The following is a description of a gene set: Binding to an adenyl nucleotide, an adenosine esterified with (ortho)phosphate. Human Gene Set: GOMF_ADENYL_NUCLEOTIDE_BINDING studied in species Homo sapiens, and this is the list of marker genes: FCSK, CDK14, UBE2G2, RNLS, SEPHS1, CHD7, ALPK2, MYO9B, ITPKA, SULT2A1, MTHFD1L, EHD3, CHD8, PSMC5, CDK10, DDX39A, NLRP2, STK38, STYK1, PSTK, DGKQ, ABCC9, LRGUK, PAK5, TREX1, STARD9, LTK, DPH6, MCCC2, ATP10B, MASTL, ATP2A2, MAPK10, CARNS1, HSP90AB3P, ATP13A3, IQCA1, EPRS1, MLH1, MAPK3, DAPK3 (NCBI Gene Id 1613), ATAD1, BRSK1, HADH, ENPP1, TRIB3, UGDH, ABCB6, RUVBL2, FER, CSF1R, MAT2A, DNAH5, RNGTT (RNA guanylyltransferase and 5'-phosphatase), RAD50, NEK1, DYRK1A, SIRT7, ABL1, CSNK1G3, NEK4, PIP5K1C, TRIT1, PANK3, DHX38, DHX36, PFKL (NCBI Gene Id 5211), PPIP5K1, PIK3CB, NLRP8, CDC6, PC, KARS1 (lysyl-tRNA synthetase 1), MUSK, PSMC6, PRKACG, DALRD3, MYO1G, ATP9A, HFM1, ADCK2, MYH6, PRKY, CNGA1, HIPK1, ASPDH, ABCC2, FARS2, CLCN7, NEK7, MYH9 (myosin heavy chain 9), PAK1, UBA1, SCYL2 (NCBI Gene Id 55681), TXK, SMCHD1, TOP2A, EPHA2, GUK1, SPG7, FN3K, ITPR3, POPDC2, DDX27, PIK3C3, MCM9, DDX23, CLPB, SBK1, CACNA1B, MARS2, DDX60L, PRKAG3, WRN, SIRT1, PDE2A, UBE2L3, FBP1, HELQ, TDRD12, MAP3K10, DNAH9, DNAH7, ACSL6, PRKAR2A, CCT4, POR, DNAH1, RIOK3, HSPA2, PMVK, RIGI, SRPK1, SLC22A5, MCMDC2, ORC5, DGKG, XRCC5, ULK4 (unc-51 like kinase 4), DDX50, NRBP1, DHX37, FPGS, DDX51, CKMT1A, ABCB1, ALDH1A1, FIGNL1, ATP2B2, DCLK2, TTLL12, ABCG5, EIF4G1, AK4, CHORDC1, PDK2, PGD, WNK4, MYO9A, UBE2O, NLRP7, NTRK2, PAPSS2, DNA2, GLUL, UBE2C, PGS1, HSPA5, DDX19B, CMPK1, SCYL3, HSPA6, EPHA5, PHKG1, HSP90AA5P, CKB, AAK1, KCNAB1, CDK13, NRBP2, HLCS, SUCLG2, ACSM2A, NEK11, ATP2A1, GCK, IRAK1, DNHD1, CCT2, STK32B, FIGNL2, BAG3, CHST15, ATP2B3, ATP8B3 (ATPase phospholipid transporting 8B3), ACSBG1, MAP3K4, CKM, ACTA1, PKLR (pyruvate kinase L/R), EGFR, PRKAR2B, EHHADH, IDNK, KIF14, EHD4, YARS1, FGFR3, KIF11, NLRP9, TAF1 (NCBI Gene Id 6872), CDC123, PIK3C2A, ITM2B, HPGD, UBE2D2, MAPKAPK2, PHGDH, EPHB2, ABCC1, DTYMK, NEK8, MAPK4, IDE, DPYD, GLUD2, ATP8B4, RPS6KC1, PCCB (NCBI Gene Id 5096), AURKC, CRYZ, ORC1, ADCY1 (NCBI Gene Id 449484), STK17A, SYN1, FMO4, ITK, PI4K2A (phosphatidylinositol 4-kinase type 2 alpha), RUNX3, OPLAH, DCK, BCS1L, TIMM44, BUB1B, JAK1, PAK2, BAG5, RHOBTB3, FMO5, KIF18B, MYO3B, BTAF1, HNRNPU, TRIP13, KIF25, KIF12, FASTK, CAMKK2, EPHA4, ACACA, CCT8, TTLL11, UBE2B, HSPA1A, TTLL5, GALK1, ENTPD8, GSR, UHMK1, EPHB4, CCT5, TLK2, ACSF3, FAM20B, MYO5A, ACTR2, STK32C, KIT, RPS6KB2, ACSS3, ACOT12, WRNIP1 (NCBI Gene Id 56897), HSP90AB1, UBE2T, PDK4, NAIP, LONP2, RUNX2, RPS6KA5, ACTA2, CLPX, AFG1L, ROS1, KIF13B, UBE2K, CRYL1, PIM2, IQCA1L, MYO18B, CDKL5, PNPLA8, MORC2, STK3, DHX34, PIK3CD, TTN, NAV2, STING1, ERCC6L2, MYO10, ATM, NUAK2, KIF2A, ITM2C, FLAD1, ADCY2, HYOU1, HSP90B1, PDE4B, NLRP12, ATP2A3, UBE2Q2, FLT4, PKN1, NUBPL, MAP3K9, NAV3, TESK2, MYO5C, PRKD3, DUOX1, ALDH1A3, PIK3C2B, TAOK2, RAD54B, STK4, PPCS, DYRK1B, UBE2G1, MYH3, ZGRF1, UBE2I, EIF4A1, MAPK13, TK1, MATK, GRPEL1, IDH1, CHUK, GRK2, EIF2AK3 (eukaryotic translation initiation factor 2 alpha kinase 3), DDX11L8, DDX18, CBR3, PKN2, TWNK, TNK1, MCM3, ATP6V1B1, SYN3, RPS6KA2, CLK3, GRK4, RFC2, BDH2, ATP9B, RARS1 (arginyl-tRNA synthetase 1), NUDT6, TK2, RAPGEF4, SIK3, MOS, CAMK4, FYN, NOS3, MAP4K3, ABCG1, NLRP3, CNGA2, DDX4, NLRC5, SELENOO, KIF2B, STK31, NUBP1, SMC4, MOK, HELLS, PFAS, KIF13A, PFKFB1 (NCBI Gene Id 5207), AFG3L2 (NCBI Gene Id 573970), KIF26B, ALPK1, MYLK2, TBK1, BAZ1B, BVES, AK1, ACTG1, ERCC6, PRKX, MET, ZRANB3, GART, FICD, MAB21L1 (NCBI Gene Id 4081), WEE2, CDK6, RUNX1, CTBP1, NDOR1, UCK2, OAS3, PDE4A, TWF2, TP53RK, PKMYT1, WEE1, DYRK2 (NCBI Gene Id 8445), GRK5, NADK, NADSYN1, ACSS1, ACVR1B, PARP15, ACTR1A, PMS1, RAD54L, CLP1, RET, HSP90AB4P, ABCA10, RPS6KB1, ROR1, CCT8L1P, MELK, ACTR1B, CLCN5, TLK1, PI4KB, CHEK2, SRC, ABCB7, NNT, DARS2, AGK, HSPD1, RFC1, TNIK, KIF2C, SLC27A5, NMRK1, KCNJ10, TTLL9, IDH3G, CDK5, CNGA4, IRAK4, KCNJ8, MINK1, ADCY5 (adenylate cyclase 5), TTLL10, SMARCA2, EEF2K, TOR1A, MYO19, CLCN4, UBE2U, ABCA2, HSPA9 (heat shock protein family A (Hsp70) member 9), HCK, TRIB1, RIMKLB, AK3, NLRP13, PBK, KIF19, STRADA, HK1 (hexokinase 1), UBE2E2, HSP90AA2P, BLM, DDX60, DDX17, NLRP11, ATP13A4, CPS1, PRKCG, DHX40, ATP8B2, NME7, PAPOLA, DNAJA4, PEX1, LIMK2, BMPR1A, ACVR1C, MAP4K1, SARS2, GRK6, TTF2, DHX9, ETNK1, CCT6A, DHX57, EIF2AK4, GK2, PFKM, EP400, STK26, ATP7B, KIFC3, HSP90AA4P, ITPKB, MSH2, CDKL4, NEK3, RAD51C, MMAB, DCLK3 (doublecortin like kinase 3), MCM7, SWAP70, RTCA, POMK, ABCC11, DDX11, UPF1, GLYR1, HMGCR, SIK2, FGR, DDX56, PRPS1L1, RPS6KL1, DDX39B, CDK2, ABCC4, SRCAP, SLFN5, RAD54L2, IPPK, TRPM4, KATNA1, MAPKAPK3, SULT1C3, MARS1, ATP11B, PTK2B, CDK20, MYO5B, DDX52, PAICS, KIF17, PDIK1L, RBKS, RYR1, YTHDC2, ULK2, FMO1, PANK2, DARS1, KIF20A, TTBK1, DAPK1, SGK1, MCM6, ABCD1, ATRX, OXSR1, PI4KA, NSF, UBA2, PAN3, GK, PDK3, FMO2, VCP, TEK, NTRK3, CASK, AMHR2, BMX, ACTBL2, DDX20, ATP13A5, ADCY7, ACSF2, UBE2E1, NLRP14, KIF9 (kinesin family member 9), PPP5C, PRKCD, TTK, TYK2, SBK3, NLRP4, PRKAG1, TRAP1, PMS2 (NCBI Gene Id 91271), PIM3, SLC12A3, ABCD2, FBH1, MSH4 (mutS homolog 4), HSPA14 (heat shock protein family A (Hsp70) member 14), MCCC1, RECQL, ULK3 (unc-51 like kinase 3), TRNT1, PAPSS1, SNRNP200, CDC7, HCN4, CENPE (centromere protein E), MAT1A, TTLL8, RUVBL1, ACLY, MYO1C, PRPS1, SIRT3, ABCA3, CBR4, ABCE1 (NCBI Gene Id 6059), STK39, SLC22A4, RAD51, LYN, AK7, MAP4K5, ACACB (acetyl-CoA carboxylase beta), DDX1, CCAR2 (NCBI Gene Id 57805), AKT3, MTHFD1, HKDC1, ABL2, PEX6, LIG4, GK5, NAXD, NTRK1, VPS4A, EIF4A3, ITPKC, PRKAR1A, TRPM7, MAGI1, FKBP4, ACTB, BRSK2, P2RX3, OLA1, PIP4K2B (phosphatidylinositol-5-phosphate 4-kinase type 2 beta), THRAP3, DNAH3, PRKAR1B, TP53I3, TAOK1, SPR, ERCC6L, CDK17, DDX10, CLK2, MYO1B, HELZ, MAST2, BBS12, CHKB, ABCC10, IRAK3 (NCBI Gene Id 11213), DDX3Y, ASS1, CERK, ABCA8, FN3KRP, DGUOK, EPHA6, CSNK1G2, DDX3X, KIF3B, CDK7, BRAF, MAPK12, NEK10, LATS2, DGKA, CNBD2, P2RX2, TTLL13, NAGK, DNAH8, MYO1D, MKI67, MAPK9, KIF4A, PEAK1, VPS4B, RARS2, RAPGEF2, DDX24, MCM4, BMS1, ERN1, PANK1, SLFN14, FIGN, NMNAT2, PTK6, SLC19A1, ITPK1, CFTR, NEK6, SORD, ATP6V1B2, NUBP2, VRK3, FGFR2, IARS1, ADCY9, SNRK, PI4K2B, CSNK2A3, CDC42BPG, ACSL4, KIF5A (NCBI Gene Id 84710), DUS2, CHD5, AKR7A3, HSPA12B, ACSM1, MKNK1, SCYL1, PNKP, FGFR4, MAP2K7, KIF1C, NPR1, SMC1B, MAP3K7, GAK, TARS3, ATP8A2, KIF23, ATP1A3, SUPV3L1, IP6K1, ATP13A1, RFC5, NME2 (NME/NM23 nucleoside diphosphate kinase 2), BMP2K, PTK7, CAD (carbamoyl-phosphate synthetase 2, aspartate transcarbamylase, and dihydroorotase), TAP1, SBK2, NOD1, NLRC4, TRPV1, KDSR, MAP3K20, MAPK14, MYH2, SIRT4, DDX5, MYO7B, TOR4A, KHK, NDUFA13, KIF1A, HSD11B1, BBS10, AASDH, CARS1, PAK4, ACSM4, DDR2 (discoidin domain receptor tyrosine kinase 2), PRKCB, CUL9, PRKG2, MYO7A, MAP3K3 (mitogen-activated protein kinase kinase kinase 3), SGK2, PRKAA2, TOR3A, MYO1A, AKT1, TARS1, PASK, DCAF1, CHD1L, HSPA1B, AOX1, STK16, GRK7, DGKH, MYO1H, CAMK1D, DHX8, TTLL6, SGK3, XRCC3, OAS1, SMARCAL1, KSR1, ROCK2, AFG2A, AACS, SPHK1, EARS2, DDX12P, ARAF, HADHA, MYLK3, ADCY6, GET3, ADCY4, ATP1A4, DDX31, AK8, ABCA5, PRKCA, EHD1, ME2, AKT2, ETNK2, NOX5, NLRP6, ERBB3, CTPS1, DNAH6, MAP3K1, MAP2K5, ATAD2B, HASPIN, PARP9, DYNC1LI1, H6PD, PKN3, CMPK2, ATP2C2, GUCY2D, CYBB, DNAH17, CAMK2D, MAST4, ALPK3, CKMT2, ATP5F1B, CSNK1E, RIOK2, STK10, POPDC3, MOV10L1, QRSL1, RFC4, GUCY2F, TM7SF2 (transmembrane 7 superfamily member 2), IDH3B, CDK19, CHTF18, NOL9, NLRP5 (NCBI Gene Id 126206), CHD1, CHD2, STK36, ATP11A, MYH1, MARK3, PAK6, GAL3ST4, KTI12, DGKK, KIF21B, P2RX7, STK40, BCKDK, KIFC1, CCT3, ERCC3, HSPE1, KATNAL2, TTBK2, ATP13A2, MAPK1, KIF1B, GLUD1, GATC, SMARCA1, KIF6, UST, EIF4A2, IDH3A, HCN3, YARS2, GMPS, RIPK1, ABCG8, TENT4A, PRKCE, WNK2, CLK1 (CDC like kinase 1), NME2P1, DHFR, CTPS2, LBR, DYNC1LI2, ENTPD3, ABCA7, AURKB, SRD5A1, FARSB, HS3ST5, MTPAP, KIF26A, TBCK, DDX53, WNK1, HCN2, SIL1, CSNK2A1, P2RX1, PALS1, ALDH1B1, SRPK2, ABCD3, CCT6B, N4BP2 (NCBI Gene Id 55728), UBE2Z (NCBI Gene Id 65264), DNAH10, RAD17, GCLC, CDKL3, ATP6V1A, DCAKD, SIRT5, SLFN13, UBE2J1 (NCBI Gene Id 51632), SLC27A3, STRADB, MYH8, TSSK1B, RIPK3, ACSL3, UBA7, PXK, TWF1, TRMU, SUCLA2, BCR, PRKG1, PRKCZ, DNAJA1, PARP1, SMARCA4, KCNJ1, BAG1, ACTR8 (actin related protein 8), XYLB, MYLK, SYK, VDAC1, HSPA8, UBA6, NME6, BAG4, NARS2, UBE2H, TGFBR1, PLK3, THG1L, XRCC6, ANKK1, SRPK3, P2RX5, KIF20B, TTLL2, ZC3HAV1, MLH3, NARS1, NDUFS2, FMO3 (flavin containing dimethylaniline monoxygenase 3), TTLL3, TKFC, NTPCR, AARS2, NOLC1, SHPK, XRCC2, GRK3, AARSD1, HSD17B1, ATP2C1, ATP5F1A, KIF4B, ALK, KIF5B, UBE2M, ALDH18A1, STK19, PDXK, PINK1, TSSK2, NIM1K, HSPA7, AATK, ATP5F1D, MYO6, KALRN, RPS6KA3, CDK9, CAT, SMC2, SRR, TOP2B, PDPK1, EPHA10, TEP1, MAGI3, SRMS, ABCB11, KIF16B, HARS2, GRPEL2, AARS1, HSP90AA1, EPHB6, TPK1, ME3, TSSK6, NLRP1, TTLL4, ABCA13, SLK, RIPK2, ABCD4, UBE4B, ABCC8, TENT2, SLC12A4, TNNI3K (TNNI3 interacting kinase), GARS1, NLRC3, CAMK2A, MAPKAPK5, PIKFYVE, UBE2N, NLRX1, MPPED2, ORC4, ABCF3, ABCA9, YES1, LRRK2, GPHN, CAMK1G, LDHB, CSNK1D, NAT10, PRKCH, EPHA1, CRYM, PFKFB4, EHD2, MYO1E, MAP2K1, UBE2J2, UBE2D1, ABCA4, ATP2B4 (NCBI Gene Id 54594), NLK, LRRK1, RPS6KA6, KIF5C, CLCN3, MAP3K19, VDAC2, SLFN11, PRKDC, ZAP70, UBE2R2, AQR, GAPDHS, KATNAL1, UBE2L5, PSMC2, MSH5, TESK1, TENT4B, SKIC2, PLK4, CDK3, MAPK8, DDX46, SEPHS2, MYH7B, ADCY3, MAP3K6, PLK2 (polo like kinase 2), INSR, BLK, SLFNL1, PDE4D, NT5C2, P2RX4, INSRR, KIF3A, TRPM6, RRM1, PSMC1, CARS2, ACSM2B, GAPDH, MYO18A, VARS2, CGAS, MAST1, ENTPD2, PPIP5K2, CLK4, DNAH11, MAP3K21, EPHA7, ACSM3, NME3, MAPK11 (mitogen-activated protein kinase 11), GMDS, PLK5, UCK1, ABCG4, MVD (NCBI Gene Id 4597), LARS1 (leucyl-tRNA synthetase 1), ATP2B1, CAPRIN1, ATP12A, PIP5K1B, CDK12, ITPR2, CSNK2A2, SMARCAD1, P2RX6, ABCA12, CDC42BPA, PIP4K2A, KIF3C, ATP8A1, ATP8B1, MCM8, HSP90AB2P, PSKH1, IRAK2, RPS6KA4, ATR, ATAD3C, GSK3A, TUT1, STK33, AFG2B, C8orf44-SGK3, ADCK1, CDK8, IGHMBP2, RAD51D, DQX1, KIAA0232, STK11, PDGFRB, ABCC6, SMG1 (SMG1 nonsense mediated mRNA decay associated PI3K related kinase), LIG3, CTBP2, GSK3B, NPR2, MTHFS, PSMC3, SYN2, CHKA, SMC6, LMTK3, TGFBR2, DYRK3, WNK3, CHST12, SARS1, SMC3 (structural maintenance of chromosomes 3), CSNK1G1, MTHFR, GPD1, HARS1, DDX41, HUNK, PRKAA1, CFAP45, GSS, TOP1, HSPBP1, MAP3K5, DDX55, NRK, NWD1, PIP5K1A, H1-7, CIITA, MYO3A, DDX59, ERBB4, NEK5 (NCBI Gene Id 8381), NADK2, ERCC2, DHX29, ABCG2 (NCBI Gene Id 9429), ATAD5, NLRP10, NOX1, MYO15A, HELZ2, PRKCI, TOR2A, TSSK3 (NCBI Gene Id 81629), EIF2AK1, HELB, KDR, GATB, MAK, HIBADH, HSPA4L, ACTC1, KIF18A, HSPH1, ALDH2, SPAST, TDRD9, EPHB1, CDK4, CDK16, KIF24, HCN1, MYH7, DYNC1H1, DDX28, DDX19A, STK25, YME1L1, ME1, GRHPR, CDK1, ABCB9, DNAJA2, NOS1, CDKL1, SMC5, CHD6, PAK3, DHX33 (DEAH-box helicase 33), ADCY10, FANCM, MVK, TTL, MSH3, EPHA3, MCM2, MYLK4, AK9, PTK2, CAMK2G, RYK, POLQ, MYH10, CAMK2B, TOR1B, ACSL1, UBE2D4, SIRT6, MAP3K14, GRK1, MAP2K4, MAPK6, PLK1, GNE, MYH15, NME4, CDK11A, UBA5, ATAD3A, MKNK2, MERTK, DDX21, RICTOR, RTEL1, COQ8A, HSD11B2, RLIG1, PFN1, CAMKV, HK3, DMC1, SPO11, RIMKLA, CDK18, MYH14, AK6, G6PD (glucose-6-phosphate dehydrogenase), DAPK2, TAOK3, P2RY1, PAPOLB, DGKZ, PKDCC, TCP1, STK24, HSPA1L, MAP3K13, SPHK2, ABCF2, EPB42, LATS1, TNK2, MAP3K8, FLT1, UBE2A, DYRK4 (dual specificity tyrosine phosphorylation regulated kinase 4), NME1, PARP14, MAP3K12, ABCC12, DNAH14, APRT, SLC27A2, TAP2, ACVR2A, PARS2, CRYZL1, PIF1, IGF1R, TARS2, TEX14 (testis expressed 14, intercellular bridge forming factor), MYH4, PRKACB, CLCN6, ATP1A2, UBE2E3, ABCB8, MIEF1, ABCB4, DDX54, KIF22, IFIH1, IPMK, TTLL1, PALM3, DDX25, ADH4, PFKP, STK17B, VRK2, PIK3R4, ADK, COQ8B, ASNS, EPHB3, RIPK4, COASY, TSSK4, GPD1L, DHX32, OBSCN, MSH6, CDKL2, KIF21A, QARS1, AXL, PKM, UBE2S, CNNM2, UBE2QL1, TYRO3, VWA8 (NCBI Gene Id 23078), DHFRP1, DDR1, FGFR1, NVL, MTREX, FAM20C, WARS2, PRP4K, CAMK1, DICER1, HSPA12A, CSNK1A1, MST1R, RAD51B, CDK11B, DDX42, GLYCTK, RPS6KA1, MARK1, FLT3, JAK3, FES, BMPR1B, MARK2, APAF1, CHD4, NUAK1, MKKS, HIPK3, ACSS2, HSPA4, MDN1, MYO16, MAP2K3, SIK1, NEK2, CAMKK1, BMPR2, DDX47, ACTR3, HIPK2, CHEK1, EIF2B2, CHD3, SRXN1, MYH11, LARS2, SHPRH, ACTR3B, PAPOLG, AK2, DHCR7, ACVR1, VARS1, NEK9, MAP4K4, LANCL2, MOV10, KIF7, HACL1, SMARCA5, MARK4, ABCA6, LIMK1, CDK15, RALBP1, EIF2AK2, ABCC5, PDE10A, PSKH2, STK35, CIT, ACSL5, MLKL, SULT1A1, ERBB2, ROR2, IARS2, QDPR, CCT7, DSTYK, PDGFRA, CDC42BPB, PGK1, MAP3K2, ATP10D, DCLK1 (NCBI Gene Id 9201), BAG2, BRIP1, RIOK1, MAP4K2, LCK, UBE2F (ubiquitin conjugating enzyme E2 F (putative)), TIE1, PIK3CA, PSMC4, KIF27 (kinesin family member 27), PRAG1, ROCK1, CSNK1A1L, GAL3ST3, CKMT1B, ACTG2, NMRK2, LONP1, DHX58, DNAH12, JAK2, OAS2, ATP7A, RECQL5, DHX35, ULK1, AK5, PFKFB2, IP6K2, ACSM6, TDG, NDUFV1, CDC34, PTPA, DHX15, IDH2, ABCC3, GUCY2C, DDX49, PIK3CG, PANK4, PRKAG2, KIF15, MTRR (NCBI Gene Id 4552), DHX30, DHX16, ABCF1, SPEG, POTEKP, DHFR2, MYO1F, ATP10A, PIK3C2G, ABCB5, RFK, ENTPD1, RAPGEF3, CCT8L2, STKLD1, ATP4A, MOCS3, HK2, PNCK, ABCB10, HSPA13, PRPS2, KCNJ11, TRIO, LMTK2, RAF1, EPHA8, BTK, HLTF, KIFC2, NMNAT1, PYGL, ITPR1, PFKFB3, RECQL4, PRKACA, UCKL1, NOS2, ASCC3, PRKD1, ATAD2, RNASEL, ATAD3B, RNF213, ILK, MAP2K2, ACSM5, CSK, ADCY8, UBE2Q1, FRK, TEC, DGKD, SETX, DGKE, MTOR, IKBKE, DGKI, HSD17B8, RSKR, UXS1, CNGB1, ACSBG2, IKBKB, IP6K3, ABCA1, ACVRL1, PDK1, STK32A, TRPV4, ACTR3C, HIPK4, PCCA, DMPK, KSR2, DNAH2, PEBP1, MAPK7, UBE2W, MAST3, NOD2, HSP90B2P, MCM5, PIP5KL1, DECR1, PRKD2, PGK2, NMNAT3, MAPK15, UBE2D3, DDX43, G3BP1, WARS1, CILK1, AURKA, ACVR2B, SIRT2, MYH13, KIF28P, DNAJA3, PHKG2, ATP1A1, MAP3K15, SMC1A, MAP2K6 (NCBI Gene Id 5608), AGAP2, FARSA, UBA3, DDX6, PIP4K2C, ATP11C, PRKCQ, GALK2, INO80, STK38L, BUB1, ERN2, DGKB, LIG1, CHD9, PIM1, VRK1, TTLL7, MAP3K11, DYNC2H1